Given this list of marker genes AKT3, AKT1, NRG4, MATK, HBEGF, NRG3, PTPN18, EGF, UBB, BTC, UBA52, ERBB2, EREG, ERBB3, UBC, CDC37, RNF41, AKT2, CUL5, PTPN12, EGFR, NRG2, ERBB4, ERBIN, NRG1, RPS27A, USP8, HSP90AA1, STUB1, here is a description of the gene set: studied in species Homo sapiens Human Gene Set: REACTOME_DOWNREGULATION_OF_ERBB2_SIGNALING Downregulation of ERBB2 signaling